The following is a description of a gene set: Human Gene Set: GOBP_RESPONSE_TO_IRON_ION species: Homo sapiens Any process that results in a change in state or activity of a cell or an organism (in terms of movement, secretion, enzyme production, gene expression, etc.) as a result of an iron ion stimulus., and this is the list of marker genes: CCNB1, CYP1A1, SLC25A39, SNCA, TFF1 (trefoil factor 1), TF, SLC11A2 (NCBI Gene Id 4891), B2M, ALAD, ATG5, PDX1, BECN1, CYBRD1, HAMP, MAP1LC3A, G6PD, CPOX, TFRC, LCN2, HFE, TFR2, BCL2, HIF1A, ACO1, TFAP2A (transcription factor AP-2 alpha), DRD2, MDM2, SLC6A3, FXN, BMP6, CCND1, ABAT